The following is a description of a gene set: Human Gene Set: HSD17B8_TARGET_GENES from publication Yevshin I, Sharipov R, Kolmykov S, Kondrakhin Y, Kolpakov F (PMID 30445619) Genes containing one or more binding sites for (HSD17B8) in their promoter regions (TSS -1000,+100 bp) as identified by GTRD version 20.06 ChIP-seq harmonization. studied in species Homo sapiens, and this is the list of marker genes: KIF2C, CENPN, HOXD12, EMC3-AS1, TMEM97, CDC25C, NBR2, THAP8, STXBP5L, SKA1, SLC30A3, EMC3, CTCF, NR5A2, PCNT, DLGAP5, FEN1, P2RX2, SETD5, DTNA, SLFN11, CCDC12, SYCE2, LIPT2-AS1, CD46P1, GPR19, HCG21, ALG10, EDC3, NPAS3, H2AZ2, EMC4, ZFPL1, HOXA3, PLK1, CIDECP1, ABCB6, MRPL45, BMPR1B, TMEM216, HOXA-AS2, TTK, ENSG00000243620, MCM10, NUP37, TENT5B, ZGRF1, ZNF833P, RFC5, TEDC2, CCHCR1, SIM1, ASF1B, ESCO2, MXD3, DZIP3, C19orf48P, UBE2C, IPO11, ESRRG, TNKS, RMI2, ZNF726, CENPF, MIS18BP1, CDKN2A, MRFAP1L2, WNK1, ZNF519, FOXN2, RNU2-17P, NUDCD2, TRIM59-IFT80, ZNF724, RAD51B, CMSS1, SGO1, ZNF732, RCCD1, CR1L, RFX2, PCLAF, TMEM245, H2AX, AURKB (aurora kinase B), MYBL1, MIR6068, C8orf33, ULBP1, NRN1, FIRRM, POC1A, REXO5, METTL4, MECOM, FADS2 (fatty acid desaturase 2), DLX6 (NCBI Gene Id 1750), MALT1 (NCBI Gene Id 10892), DLX6-AS1, IFT80, NUP107-DT, LINC01391, CEP152, FANCC, KIF18B, FAM110A, CIP2A, UHRF1, XRCC3, ERCC6L, RFWD3, HMGB3, PBK, FBXL9P, PRCP, ARID3B, NDC80, KNL1, HHIP, SLBP, EPHA5, RBM15, DUT-AS1, ENSG00000232732, AP4M1, TDRKH, E2F3, FKBP3, ANKRD24, METTL18, ZFYVE21, CDK1, NKX3-2, LINC02977, VSNL1, HOXC6, CTCF-DT, GFI1, WEE1, HJURP, CEP192, COX8A (NCBI Gene Id 1351), SH3GL1, PAX6 (paired box 6), FANCB, RUNX3, FHL1, BRD9, LGR5, TCEA1, MOSPD2, KLHL12, POLQ, ZNF138, SHC1, ING2-DT, FAM76B, HNRNPD, GTSE1-DT, POLD1, RECQL, MKI67, KNTC1, FENDRR, TRAIP, HAUS8, C3orf38, RAD9B, MRPL27 (mitochondrial ribosomal protein L27), ATAD3B, MIR9-2HG, BAMBI, ENSG00000263080, UNG, BORA, LMF2, EMX1, DKK2, CEP89, ALDH1A2-AS1, PRIM2, KCTD9, KIF20A, KMT5A, BRIP1, NEMP1, PHOX2B-AS1, FBXO5, FAM111A, ATP2A1-AS1, TBR1, FAM200B, FERRY3, FANCD2, H2AZ2-DT, C1orf35, NET1, C2orf69, HOXB3, OSTM1, CDC6, OBI1 (NCBI Gene Id 86572), ZNF718 (zinc finger protein 718, NCBI Gene Id 255403), PTRHD1, TIMM21, CEP295, DLEU1, TRBV23OR9-2, POLG, EIF2AK3, ANLN, DUT, MAEA, RSRC1 (NCBI Gene Id 51319), ZNF430, ARHGAP19-SLIT1, LTN1, INTS14, APOBEC3B, APLF, PSMC3IP, TRIM59, DTL, LRRC14, SPC25, AHCTF1, NCAPD3, ZNF682, AIRIM, ZNF678, SHQ1, NFATC2IP, NSD2, H2AZ1, TLX2, MAP3K11, ZNF367, MCIDAS, H2BC16P, CEP43, SGO2, LHX8-AS1, DLEU2, CDIN1, NEU1, TDP1, GTSE1, HNRNPD-DT, IQGAP3, EPHA5-AS1, LIM2-AS1, CEP192-DT, RFC3, SASS6, IGF2BP1 (insulin like growth factor 2 mRNA binding protein 1), TMEFF2, LNCRNA-IUR, KMT5C (lysine methyltransferase 5C), HOXB4, KIF15 (NCBI Gene Id 56992), H2BC11, CDCA7, GINS1, E2F8, CDH11, CDC20, ENTREP2, SHCBP1, KIF20B, SPAG6, TCERG1, ZNF273, CDC23, KIF23-AS1, CCNA2, RHNO1, INTS12, MIR924HG, BHLHE22, PHOX2B, HPGD (15-hydroxyprostaglandin dehydrogenase), SNRPD2, VGLL2, CCNE1, FBXL20, NEK2, HROB, MRPL57, C1orf159, DGCR8, PGK1, USP5, MLLT1, CENPX, SLC24A1, MCM8, RAD51-AS1, ARHGEF39 (Rho guanine nucleotide exchange factor 39), TICRR, HEY2, TULP3, ATAD5, MIS18A, SNHG5, FOXCUT, COG1, ELMOD1, SKOR2, LBX1-AS1, CHEK2, DDIAS, H2AZ1-DT (NCBI Gene Id 256880), FEZF1-AS1, KIFC1, EVX2, TK1, PRDM13, FAM222A, LHX8, CKS1B, ARHGAP11A-DT, CEP57, CDCA5, ZNF90, FOXI3, HYAL2, RTKN2, NUDT15, LIN9, CIT, SBSPON, ARX, CACNB4, AGFG2, POLE3, ZNF331, MAP3K7, PRR11, ENSG00000232995, GINS3, IFI27L1, C7orf57, PLCXD1, CDC25A, NCAPG, LINC02587, WDR62, MZT1, BLM, CENPS-CORT, ZNF687, ARHGAP19, H2AC11, CMC2, MCM5, ADGRV1, BRCA1, CDCA3, GOLT1B, TROAP, TMPOP2, C1QTNF6, MTAP, RAD18, DEPDC1, E2F2, LENG1, PLK4, MCM6, ZNF43, DNA2, KIAA1143 (NCBI Gene Id 92278), ZNF736, RNF220, ANP32E, H2BC27P, CKAP5, C5orf34, TMPO-AS1, ITGAE, INTS7, KPNA2, HCN3, GATA3-AS1, VPS29, MSC-AS1, CCDC150, SFRP2, TBC1D31, EIF3F, CHD7, PPWD1, FOXA1, LINC01475, KCNMB4 (NCBI Gene Id 27345), RAD51 (RAD51 recombinase), RPL39L, FAM83D, TCF19, COX5AP1, DNMT3B, TMEM129, ZW10, NDNF-AS1, MAD2L1, HPSE2, BIRC5, ZNF738, GEN1, MSH5-SAPCD1, SLU7, ZNF785, RPUSD1, NFIB-AS1, HASPIN, LHX6, CEP128, TAL1, GATA3, LSM5, MRPL13, GUCY1B1, TOPBP1, AARS2, POLG-DT, RCC1, ADRA1A, TMEM208, PIMREG, NEUROG2, TTF2, POLD3, PARPBP, RPS20, FRG1CP, SP4 (NCBI Gene Id 6671), LINC02482, CERNA3, ENSG00000224905, SOX7-AS1, ZNF689, GPSM2 (NCBI Gene Id 29899), TMED5, BRD8, INHCAP, ASPM, NEK2-DT, GLB1L3, RBL1, MELK, DIAPH3 (NCBI Gene Id 81624), NCAPG2, PEX19, SPAG5, TPTEP2, MCM3, SOX9-AS1, ERG, MSH5, C12orf75, SKA2, VPS26B, NUDT2, CHTF18 (chromosome transmission fidelity factor 18), NCAPH, NOL8, PNO1, ZFHX3-AS1, BUB1 (NCBI Gene Id 699), CDCA2, SMC6, FANCM, INCENP, GINS2, PRC1, SNCA, CDKN2C, TOP1, KIF14, NUF2, KIF22, POU4F1, KCTD21-AS1, ZNF66, HNRNPAB, CASP8AP2, SMC4, CENPP, H2AC16, POLE, TEDC1, CLVS2, FBXL5, KIF18B-DT, SLC35B1, MNS1, MASTL, ZNF688, THUMPD3-AS1, PITX1-AS1 (PITX1 antisense RNA 1), ESPL1 (extra spindle pole bodies like 1, separase), MMUT, HSCB, RBM42, LRRC45, ZNF530, TRIP13, SOWAHA, ZNF100, CD101-AS1, NAP1L4 (NCBI Gene Id 4676), ING2, HMMR, FBXO48, GFRA2, HMGB2, ZNF730, ZYG11A, LEF1-AS1, BUB1B, MTHFD1, CCDC18, LIN28B, LHX1, RGS5, IER5L, MCM7, TOP2A, STIL, CEP55, WRAP73, GATA2, ADGRL1-AS1, ZNF492, NUCKS1, GATA6-AS1, RNASEH2A, PITX1, CDCA8, H2AC13, ARHGAP11A, MTBP, EIF2AK3-DT, ZNF107, FOXD3-AS1, RFC4, MYBL2, SNORD54, XPO1, ECT2, ZAR1L, PTTG1, CENPK, LHX1-DT, DBF4B, RAD54L, UBE3D, EME1, FEZF1, PCOLCE2, ZWINT, MAD2L1-DT, ZNF695, FAM47E, TARID, CENPE, MTFR2, RPA1, SGO1-AS1, CKAP2L, NR2E1 (nuclear receptor subfamily 2 group E member 1), TMEM258, DLX1, ANKRD19P, ZNF486 (NCBI Gene Id 90649), RPPH1 (ribonuclease P RNA component H1), E2F1, SKA3, CENPA, ATP2A1, FOXM1, CCNB2, MND1, TRMT6 (tRNA methyltransferase 6 non-catalytic subunit), C6orf141, SPAG5-AS1, SATB2, EPOR, DCAF16, MYO9B, CDKN2D, SYCP2L, FANCI, RAD51AP1, ZIK1, TMOD1, ERI2, CENPS, C21orf58, THBS4, PPIH, CRTC3-AS1, LRP4-AS1, NUP107, FAAP24, SMYD4, FOXG1, ATAD3A, DNAAF10, CENPW, CDKN3, ATAD2, TACC3, EXO1, LINC01572, FAM53C, FBXO15, RCCD1-AS1, DOLPP1, THAP10, YME1L1, HMGB1, HAPSTR2, ALG8, FKBP5, CLIC1, KIF23, C9orf43, RRM2, RRM1, TRMT13, GATM, PAUPAR, ISL2, CTXND1, LINC01775, PIAS1, LARP7, PAX5, XRCC2, LRRC49, CDC20-DT, TLX3, PXMP2, RNU6-1, DDX24, TDRKH-AS1, RECQL4, AFMID, EOMES, CENPI, QPCTL, FAM47E-STBD1, CENPO, TRIM36, PARP2 (NCBI Gene Id 10038), BRCA2, RSRC2, VRK1, RDM1, EMX2, NCAPH2, HOXD11, TMEM255B, RTTN, NOLC1, H2BC13, CENPQ, ATL2 (NCBI Gene Id 64225), UBE2T, SMC2, SPC24